Given this list of marker genes Synj2bp, Ankfy1 (NCBI Gene Id 11736), Plin2, Cldn34b3, Elovl2, Tes, Cdh9, Tmem64, Myo7a, Nup133, Sec16a, Slmap, Rtn4ip1, Gins4, Tmem151b, Inmt, Syne1, Ptcd3, Ms4a4c, Plekho2, Ell2, Fam184b, Bnip3, Slc25a36, Smgc, Gas2l1, Grm4, Gmnc (NCBI Gene Id 385639), Kif1b, Mrfap1, Psmc3ip, Prune2, Rnaseh1, Adipor2, Mink1, Gulo, Srsf2, Erg, Rnf135, Zmat2, Spire2, Crb2, Dtna, Gtse1, Zfp979, Mpzl1, Inafm2, Abcc5, Eftud2, Mapre1, Scrn1, Mbnl3 (muscleblind like splicing factor 3), Rpap2, Gatd1, Itih2, Ms4a8a, Msrb3, Jph4, Myo6, Peak1, Lsp1, Rab8b, Msx2, Magi3, Stc1, Plpp3, Epsti1, Six4, Sprr2k, Usp34, Cd2ap, Snx30, Irak1, Trip11, Pcdh1, Hadhb, Gng10, Nrip3, Ccdc43, Tcf12, Nbeal2, Cep350, Alkbh5, Sgk2, Lrp10, Nr2e1, Cr2, Slc25a37, Snrpb, Lcn10, Cpsf6, Ncf2, Atf7, Sycp1, Elapor1, Epas1, Edem2, Phactr1, Tmprss2, Miga1, here is a description of the gene set: species: Mus musculus Genes predicted to be targets of miRBase v22 microRNA mmu_miR_6919_5p in miRDB v6.0 with MirTarget v4 prediction scores > 80 (high confidence targets). from publication Chen Y, Wang X (PMID 31504780) Mouse Gene Set: MIR_6919_5P